The following is a description of a gene set: Human Gene Set: FARMER_BREAST_CANCER_CLUSTER_7 from publication Farmer P, Bonnefoi H, Becette V, Tubiana-Hulin M, Fumoleau P, Larsimont D, Macgrogan G, Bergh J, Cameron D, Goldstein D, Duss S, Nicoulaz AL, Brisken C, Fiche M, Delorenzi M, Iggo R (PMID 15897907) species: Homo sapiens Previous microarray studies on breast cancer identified multiple tumour classes, of which the most prominent, named luminal and basal, differ in expression of the oestrogen receptor alpha gene (ER). We report here the identification of a group of breast tumours with increased androgen signalling and a 'molecular apocrine' gene expression profile. Tumour samples from 49 patients with large operable or locally advanced breast cancers were tested on Affymetrix U133A gene expression microarrays. Principal components analysis and hierarchical clustering split the tumours into three groups: basal, luminal and a group we call molecular apocrine. All of the molecular apocrine tumours have strong apocrine features on histological examination (P=0.0002). The molecular apocrine group is androgen receptor (AR) positive and contains all of the ER-negative tumours outside the basal group. Kolmogorov-Smirnov testing indicates that oestrogen signalling is most active in the luminal group, and androgen signalling is most active in the molecular apocrine group. ERBB2 amplification is commoner in the molecular apocrine than the other groups. Genes that best split the three groups were identified by Wilcoxon test. Correlation of the average expression profile of these genes in our data with the expression profile of individual tumours in four published breast cancer studies suggest that molecular apocrine tumours represent 8-14% of tumours in these studies. Our data show that it is possible with microarray data to divide mammary tumour cells into three groups based on steroid receptor activity: luminal (ER+ AR+), basal (ER- AR-) and molecular apocrine (ER- AR+). Cluster 7: selected apocrine and luminal genes clustered together across breast cancer samples., and this is the list of marker genes: FASN, ALDH3B2, SREBF1, TRIM36, MSX2, CDH1, ECI2, SCD, TMEM41B, ESRP2, ALCAM, AR, SLC35A3, DHRS2, TMEM135, IRX5, GSE1, BLVRB, GHR, RND1